Given this list of marker genes GPHN, GRM7, ARV1, EP300, SEC31A, FBXO28 (F-box protein 28), MID1, DST, SLC1A3, LRP12, NAA10, GLRA1, PIGA (phosphatidylinositol glycan anchor biosynthesis class A), MATR3, ATP1A3, CACNA1A, ATXN8OS, GRB10, DHX16, POLR1A, ENSG00000288330, LAMA2, HEXA, GNB2 (NCBI Gene Id 96628), ADNP, CREBBP, SRPX2, ATP1A2, PI4KA, FOXG1, GM2A, ADGRG1, DCX, DOLK, here is a description of the gene set: Human Gene Set: HP_ASPIRATION species: Homo sapiens Aspiration Inspiration of a foreign object into the airway.